Given this list of marker genes Nr1h2, Nova1, Hoxc10 (NCBI Gene Id 209448), Foxc2, Lnpep, Tlr4, Arrdc3, Acvr2b, Rbpj, Tfe3, Nr1h3, Acot11, Tle3 (NCBI Gene Id 70332), Bmal1, Ddit3, Notch1, Rb1, Adipoq, Actn3, Dock7, Pctp, Lama4, Cidea, Acot13 (NCBI Gene Id 66834), Atf4, Aldh1a1, Abhd6, Il18r1, Stk11, Plcl2, Flcn, Lgr4, Nrdc, Map2k6, Pgam5, Wnt10b, Adamts5, Adam17, Ip6k1, Qki, Rheb, Plcl1, Nova2, Nr1d1, Zfp423, Il15, Id1, Npr3, here is a description of the gene set: Any process that stops, prevents, or reduces the rate of cold-induced thermogenesis. studied in species Mus musculus Mouse Gene Set: GOBP_NEGATIVE_REGULATION_OF_COLD_INDUCED_THERMOGENESIS